The following is a description of a gene set: Human Gene Set: PATEL_SKIN_OF_BODY_ZOSTAVAX_AGE_70_93YO_VZV_CHALLENGE_6HR_DN Background: The live attenuated vaccine Zostavax was developed to prevent varicella zoster virus (VZV) reactivation that causes herpes zoster (shingles) in older humans. However, the impact of vaccination on the cutaneous response to VZV is not known. Methods: We investigated the response to intradermal VZV antigen challenge before and after Zostavax vaccination in participants > 70 years of age by immunohistological and transcriptomic analyses of skin biopsy specimens collected from the challenge site. Results: Vaccination increased the proportion of VZV-specific CD4+ T cells in the blood and promoted the accumulation of both CD4+ and CD8+ T cells in the skin after VZV antigen challenge. However, Zostavax did not alter the proportion of resident memory T cells (CD4+ and CD8+) or CD4+Foxp3+ regulatory T cells in unchallenged skin. After vaccination, there was increased cutaneous T-cell proliferation at the challenge site and also increased recruitment of T cells from the blood, as indicated by an elevated T-cell migratory gene signature. CD8+ T-cell-associated functional genes were also highly induced in the skin after vaccination. Conclusion: Zostavax vaccination does not alter the abundance of cutaneous resident memory T cells but instead increases the recruitment of VZV-specific T cells from the blood and enhances T-cell activation, particularly cells of the CD8+ subset, in the skin after VZV antigen challenge. Genes down-regulated in skin of body 6hr vs 0hr in adults (70-93) (VZV challenge) after exposure to Zostavax, time point 6H from publication Patel NP, Vukmanovic-Stejic M, Suarez-Farinas M, Chambers ES, Sandhu D, Fuentes-Duculan J, Mabbott NA, Rustin MHA, Krueger J, Akbar AN (PMID 30247603) studied in species Homo sapiens, and this is the list of marker genes: LINC00310, ZNF300P1, HHAT, LRRC28, ERICH1, RBM19, PRCD, CEP41, PCCA, TRPM4, ERC1, NDUFA8, RPL32P3, SUGP1, NIT1, KANK1, USP40, ANKRD13D, MRPS6, TCTA, DHX16, ACOT13, AFDN-DT, BABAM1, VPS45, AKAP1, MAP6, MAP3K4, FAHD2A, RUSC1-AS1, SHOX2, SIRT5, CUL9, BTNL9, ATG16L2, TBX5, NECAB3, SAMD1, MRPS16, TARBP2, PCGF1, NDUFV1, INTS8, PTCSC1, COX4I1, RPUSD3, LINC01550, TMEM254-AS1, PLEKHJ1, AQP11, DYNC2I2, TMEM184A, ALDH4A1, CIMAP2, COQ9, SLC9A9, CCS, SAMM50, PIGG (NCBI Gene Id 54872), HSPB3, GGCX, ALS2CL, SRY, VILL, EDN3, TFCP2, PER1, MMAB, DMAC1, FIGN, CDK5RAP3, MIR30C2, AIG1, LDAH, DUT, RFXANK, SCARB1, PRMT7, TTC28-AS1, RUFY3, SDCCAG8, ENSG00000254531, NHLH1, SEC16B, MORF4L2-AS1, SPAG8, IRX5, MED12L, SLC52A1, ARHGEF9, NUDT22, CAPN3, CARS2, ZNF32, C5orf63, ZNF341, THADA, PIN4, DCBLD1, ULK2, STX16, ELP4, TET1, PEX6, ZBTB16, TMEM63A, LINC00113 (long intergenic non-protein coding RNA 113), CEP152, ANKS6, VPS26B